The following is a description of a gene set: A clinical sign indicating a lapse of posture and is usually manifest by a bilateral flapping tremor at the wrist, metacarpophalangeal, and hip joints. Asterixis Human Gene Set: HP_ASTERIXIS species: Homo sapiens, and this is the list of marker genes: NR1H4, ATP8B1, SLC25A13, ABCB4, ABCB11